Given this list of marker genes ATRX, GHR, SOX10, ALMS1, OTUD5, RNASEH2B, HESX1, HNRNPR, FGF8 (NCBI Gene Id 2253), FGF17, TBX3, ERCC6, FKBP6, TBL1XR1, CASK, BRD4, RSPO2, EHMT1, UBE4B, DCAF17, NEUROD2, HS6ST1 (NCBI Gene Id 9394), IFT80, FAM111A, RXYLT1, NR0B1, B9D2, MTM1, POLR1C, KLHL40, TAC3, TCF12, BBS7, ADAT3, CASZ1, DYRK1A, ALX4, TP63, MYH3, MED12, CDT1, NEB, MID1 (NCBI Gene Id 8230), TCF4, B3GALNT2, RLIM, GATA4, SKI, LARGE1, DUSP6, WNT7A, SCN2A, TOE1, CTU2, SETBP1, VAC14, GNRHR, ATP6V1A, FANCD2, GNB2, PRDM16, KIF7, NODAL, KIAA0586, PRDM13 (NCBI Gene Id 59336), TTC8, SMO, DHODH, ERCC8, SGPL1, WT1, ARCN1, MADD, IFIH1, POMGNT2, RNASEH2A, SEMA3A, RAB3GAP2, FANCL, ALKBH8, GRM7, CRPPA, THOC6 (NCBI Gene Id 79228), PROK2, HERC2, PSMC1, GTF2IRD1, DHCR7, GH1, RNASEH2C, MAGEL2, CAMK2A, SCAPER, CYP17A1, PIGQ, MLXIPL, VPS37D, SOX9, PHF21A, SCN1B, NIPBL, DVL1, SIK1, FILIP1, GLYCTK, RNU7-1, DIS3L2, CHRNG, KCNA1, GABRD, DHX37, TRIM8, NPHP1, GPC4, CPE, SRRM2, STX1A, SUFU, TGIF1, KISS1R, CILK1, PWAR1 (Prader Willi/Angelman region RNA 1), PPP1R12A, PIGP, KCNAB2, COX7B, CDC6, SLC30A7, KISS1, MKS1, MMP23B, KIAA0753, PHF6, HOXA13 (homeobox A13), PIEZO2 (NCBI Gene Id 63896), CCDC22, TBX4, BBS2, CDH11, VAMP7, GMPPB, ECE1, LZTFL1, CDH2, SMC3, GLI3, NXN, CLIP2, HSPG2, MYT1L, THOC2, KDM5C, STT3A, EBF3, MBD5, POR, HID1, TREX1, NCF1, ATP6V1E1, DTYMK, PTPN11, SC5D, NEK1, TACR3, CDC42BPB, ACTA1, WNT3, PROKR2, DPYSL5, IFT74, GRIA3, ISL1, SRA1, FIG4, SRD5A2, C2CD3, LSM11, MAP3K1, SMCHD1, IFT172, FAT4, CRIPTO, ANK1, PIGA, METTL27, OPHN1, TRPM3, FANCB, EZH2, LIMK1, SOX3, ZIC2, UBR7, HSD3B2, ORC4, TRIM32, GTF2I, STT3B, BUB1B, CDON, ARX, KAT6B, DNAJC19, ROR2, RAB18, TCOF1, HCCS, MYRF, CEP41, PLAG1, GRIN1, LMOD3 (leiomodin 3), POLR1B, RNU4ATAC, ERCC2, USP7, GPC3, RERE, PRKCZ, FKRP, DDX6, NR5A1, PRKDC, KLHL15, IFT27, TAF6 (TATA-box binding protein associated factor 6), ROBO1, SLC25A24, LMNB2, FOXH1, CDKN1C, TWIST2, TSPYL1, GAS1 (growth arrest specific 1), WDPCP, SLC29A3 (NCBI Gene Id 8072), GNRH1, DNA2, ZFPM2 (zinc finger protein, FOG family member 2), EIF2S3, TBCE, RTTN, CCDC28B, DCX, PDPN, B4GAT1, HDAC8, NSMF, ARMC9, KLHL41, PWRN1, SMC1A, BBS12, PTCH1, EIF4H, CYB5A, TAPT1, COG5, MKKS, SNORD115-1, FGFR1, NDUFB11, BBS4, BBS10, DYNC2H1, BUD23, COL4A1, LUZP1, NPAP1, LEP, XRCC4, FZD2, PAFAH1B1, TBL2, CHD7, ELN, DHDDS, PRRX1, LSS, AHDC1, AXL, GRIP1, RIPK4, POMT2 (protein O-mannosyltransferase 2), PNKP (polynucleotide kinase 3'-phosphatase), COLEC10, SIM1, HOXD13, KLF1, BAZ1B, DNAJC30, POMGNT1, POLR1D, SCLT1 (sodium channel and clathrin linker 1), MINPP1, IL17RD, WASHC5 (WASH complex subunit 5), FREM2 (NCBI Gene Id 341640), YWHAE, HMGA2, SOX2, ACTB, EXT2, WDR35 (NCBI Gene Id 57539), MEGF8, RFC2, TMEM270, DYNC2I2, WDR11, OTX2, NSD1, DVL3, SPRY4, SDCCAG8, DMXL2, PBX1, SAMHD1, BBIP1, ZEB2, WNT5A, SPEN, SEMA3E, DACT1, SATB2, BBS9, FKTN, RAD21, INPP5E, FRAS1, SIX3, ARL6, DCC, SNORD116-1, WWOX, KDM6A, DISP1, CFAP418, ARNT2, ATAD3A, BBS5, POLE, LHB (luteinizing hormone subunit beta), AR (NCBI Gene Id 367), CUL4B, RAB3GAP1, PNPLA6, H4C9, MKRN3, FLRT3, DLL1, LMX1B, LIG4, CHD4, KMT2D, GPR161, INTU, POMK, RYR1, ORC6, UBE2A, ORC1, GNAO1, UBR1, NHLH2, FANCF, CDKL5, STXBP1, PSMD12, LAMA5, SIX6, IGF2, SIN3A, CDC45, TBC1D20, DAG1, MCTP2, GTF2IRD2, MAMLD1, HERC1, POMT1, VPS35L, BLTP1, CENPT, LHX4, KATNIP, TRRAP, ANOS1, TOGARAM1, ALG12, SUZ12, GLI2, UBA1, SPTBN1, CEP19, SLC32A1, GMNN, DYNC2I1, FEZF1, CEP290, RNF113A, SALL1, ADAR, POGZ, SHH, BBS1, NDNF, HUWE1, CCDC141, SAMD9, SLC25A22, ZPR1, SRY, here is a description of the gene set: studied in species Homo sapiens Human Gene Set: HP_HYPOPLASIA_OF_PENIS Hypoplasia of penis